The following is a description of a gene set: from publication Iizuka N, Oka M, Yamada-Okabe H, Mori N, Tamesa T, Okada T, Takemoto N, Sakamoto K, Hamada K, Ishitsuka H, Miyamoto T, Uchimura S, Hamamoto Y (PMID 15710396) Using high-density oligonucleotide array, we comprehensively analyzed expression levels of genes in 50 hepatocellular carcinoma (HCC) samples with positive hepatitis C virus (HCV) serology (well (G1), moderately (G2), and poorly (G3) differentiated tumors) and 11 non-tumorous livers (L1 and L0) with and without HCV infection. We searched for discriminatory genes of transition (L0 vs. L1, L1 vs. G1, G1 vs. G2, G2 vs. G3) with a supervised learning method, and then arranged the samples by self-organizing map (SOM) with the discriminatory gene sets. The SOM arranged the five clusters on a unique sigmoidal curve in the order L0, L1, G1, G2, and G3. The sample arrangement reproduced development-related features of HCC such as p53 abnormality. Strikingly, G2 tumors without venous invasion were located closer to the G1 cluster, and most G2 tumors with venous invasion were located closer to the G3 cluster (P=0.001 by Fisher's exact test). Our present profiling data will serve as a framework to understand the relation between the development and dedifferentiation of HCC. Human Gene Set: IIZUKA_LIVER_CANCER_PROGRESSION_G1_G2_DN species: Homo sapiens Genes down-regulated during transition from G1 (well differentiated tumor, infected with HCV) to G2 (moderately differentiated tumor, infected with HCV) in the development of hepatocellular carcinoma., and this is the list of marker genes: CCT6A, VEZF1, AARS1, TPD52L2, SP3, ADNP, GORASP2, ATXN2L, IMPA2, ZNF91, DICER1, ATP2A2, TSC22D2, EIF4G1, PPIB (peptidylprolyl isomerase B), SIAH1, SFPQ, PSME4, PRPF40A, UBQLN2, GOLGA4, RPN1 (NCBI Gene Id 6184), ACTB, EFCAB14, FDPS